The following is a description of a gene set: studied in species Mus musculus The controlled release of a fluid by a cell or tissue in an animal. Mouse Gene Set: GOBP_BODY_FLUID_SECRETION, and this is the list of marker genes: Alox12b, Rplp0, mt-Co2, Prl, Mmp13, Usf2, Wnk1 (NCBI Gene Id 406236), Ddr1, Xbp1, Celsr2, Gpat4, Prl2c1, Hif1a, Aqp5, Nlrp6, Tac4, Atp2b2, Socs2, Kcnma1, Prl3b1, Prl3c1, Ccnd1, Prl8a1, Vegfa, Prl8a9, Hk2, Neurl1a, Agr2, Sytl2, Ptger4, Uprt, Npr3 (natriuretic peptide receptor 3), Cdo1, Prl3d2, Enpp1 (NCBI Gene Id 97628), Prl4a1, Fgf10, Prl2c3, Prl7a2, Cad, Negr1, Abcb1a, Cel, Ncoa1, Prl2b1, Umps, Adora3, Ghrhr, Map1lc3b, Slc4a9, Slc4a5, Aprt, Neurog1, Foxb1, Prl7c1, Chrm3, Madd, Erbb4, Ada, Slc29a1, Nme1, Trp73, Csn3, Nkx2-3, Prl2c5, Atg5, Prl8a2, Vdr, Kcnn4, Prl3d3, Sct, Stat5b, Xdh, Rab14, Prkce, Chrm1, Prl3a1, Anxa2, Prl7a1, Edn1, Eif2ak3, Nr1h2, Prl7d1, Zbtb7b, Aqp1, Prl6a1, Wnk3, Prl3d1, Csn2, Prl2c2, Copa, Fosl2, Nr1h3, Prl8a6, Med1, Wnk4, Cav1, Prlr, Oprk1 (NCBI Gene Id 18388), Atg7, Kalrn, Prl8a8, Slc6a3, Egfr, Prl7b1, Tifab, Ppp3ca, Traf3ip2, Stat5a, Stk39, Ano1, Htr4, Aqp4, Trpc1, Adora1, Vamp8, P2ry2, Chuk (conserved helix-loop-helix ubiquitous kinase), Muc2, Gja1, Oas2, Prickle1, Atp7b, Creb1, Prl2a1, Cyba, Guca2b, Prl5a1, Scnn1b